Given this list of marker genes G6PC3, IFIH1, KIF11, ADA2, PSMG2, RNASEH2C, RNASEH2B, ADAR, CASP10, PSMB4, TREX1, OTULIN, LCK, MEFV, RNU7-1, FAS, RNASEH2A, PSMB8, IKBKG, FASLG, MYSM1, PTPN6, DOCK11, SAMHD1, LSM11, SERPINA1, HAVCR2, here is a description of the gene set: studied in species Homo sapiens Human Gene Set: HP_PANNICULITIS Panniculitis Inflammation of subcutaneous adipose tissue.